Given this list of marker genes KCNN2, MYL2, MYH6, OXTR, ACE, HTR2A, EDN3, KCNIP2, CHRM2, ATP1B2, MIR30E, GJC1, TACR3, DSP, THRA, SLC4A3, DOCK5, KCNE3, ADRA2B, ECE1, HEY2, TRPC1, GJA1, ADRA1B, RGS2, RNLS, ADRA1A, GSTO1, DBH, NOS1AP, FXYD1, SPX, GSK3A, EDNRB, ITGB1, HCN4, JPH4, MIR200C, ABL1, TNNI3K, KCNJ2, SHOX2, GLRX3, CLIC2, ADRA2A, MYL4, HRC, MYH7B, JPH1, KCNA5, CELF2, P2RX1, CORIN, HBEGF, MYL3, ATP1A3, APLN, ADM5, CACNA1G, ATP2B3, POPDC2, SCN3B, DES, ARHGAP42, KCND3, JUP, AGER, TH, TMIGD3 (transmembrane and immunoglobulin domain containing 3), AGTR1, ADCY10, GCH1, NPFF, ASIC2, GAA, AVP, LEP, TRDN, GJD3, TNF, GJA5, SCN5A, KCNJ3, STC1, KCNE4, JPH2, BMP10, SMTNL1, GJC3, TACR1, ADD3, ITGA4, HRH1, ATP1B1, MYBPC3, CACNA1D, APP, STRIT1, MIR328, BVES, DOCK4, MEF2A, SLC1A1, AGTR2, DLG1, NPPA, TAC1, SUMO1, IRX3, SLC8A2, NKX2-5, MIR133A1, PDE4B, ATP2B4, CYP2J2, SPTBN4, HCN1, CACNA2D1, MIR448, DSC2, AVPR1A, GNAO1, PER2, NUP155, GATA4, KCNE5, PTPN1, FAAH, MIR1-1, MC3R, TMEM38A, CAV3, SCN4B, EDN1 (NCBI Gene Id 1906), PLN, RNF207, RHOA, THRB, MTNR1B, ATP2A3, HTR1A (NCBI Gene Id 3350), CD38, GSTM2, SLC8A3, ATP2A1, IRX5, ASPH, STUB1, ADM, MYH7, CACNA1H, ADRB1, KCNH2, TPM1, DRD2, KCNE2, FKBP1B, P2RX4, SCN2B, CSRP3, SLC8A1, TMEM38B, FGF13, MMP2, TNNI3, HRH2, ADORA3, F2R, NOS1, ATP1A2, CASQ2, CASR, CAMK2D, FKBP1A, AVPR2, RANGRF, CHGA, CACNA1C, TBXA2R, FLNA, MDM2, ATP2B1, PIK3CG (NCBI Gene Id 5294), KCNIP1, AKAP9, EPAS1, FGG, TBXAS1, ATP1A1, CALM2, DSG2 (NCBI Gene Id 1829), GRK2, HCN3 (NCBI Gene Id 57657), SVEP1, TGFB2, S100A1, ZDHHC21, KCNH6, KCNQ1, ATP2B2, GHRL (ghrelin and obestatin prepropeptide), KCNMB4, ACE2, ITGA9, MIR26A1, DMPK, CACNB2, TRPA1, YWHAE, TNNT2, TBX5, KCNE1, NOS3, UCN, CALM3, ADM2, FGA (fibrinogen alpha chain), SCN1B, HSP90AA1, FGB, MIR19A, EHD3, BDKRB2, PRKACA, OXT, SCN10A, SRC (NCBI Gene Id 6714), KCNJ5, EDN2, CTNNA3, EDNRA, GPD1L, KCNJ12, ADRA1D, BIN1, CXADR, JPH3, TRPM4, HOPX, ABCC9, ADRA2C, MIR92A1, CALM1, MIR21, GLP1R, SREBF1, HSPB7, MAP2K1, TMEM161B, APELA, RYR2, NMU, PKP2, ZC3H12A, ZMPSTE24, CAV1, SLC9A1, FOXN4 (NCBI Gene Id 121643), ANK2, MIR208A, KCND2, KCNMB2, ADORA1, DMD, SNTA1, TMEM65, TBX18, ATP2A2, BMPR2, RGS4, ISL1, SRI, TBX2, ADA, SMAD7, AVPR1B, AGT, KCNJ8 (potassium inwardly rectifying channel subfamily J member 8), PDE4D, here is a description of the gene set: species: Homo sapiens Any process that modulates the frequency, rate or extent of blood circulation. Human Gene Set: GOBP_REGULATION_OF_BLOOD_CIRCULATION